Given this list of marker genes LIN28A, REXO1, SUV39H2, CRIPTO, DNMT3L, ASH2L, CCNB1, CBX7, NANOG, DPPA5, KAT6B, here is a description of the gene set: studied in species Mus musculus Human Gene Set: MIKKELSEN_PLURIPOTENT_STATE_UP Somatic cells can be reprogrammed to a pluripotent state through the ectopic expression of defined transcription factors. Understanding the mechanism and kinetics of this transformation may shed light on the nature of developmental potency and suggest strategies with improved efficiency or safety. Here we report an integrative genomic analysis of reprogramming of mouse fibroblasts and B lymphocytes. Lineage-committed cells show a complex response to the ectopic expression involving induction of genes downstream of individual reprogramming factors. Fully reprogrammed cells show gene expression and epigenetic states that are highly similar to embryonic stem cells. In contrast, stable partially reprogrammed cell lines show reactivation of a distinctive subset of stem-cell-related genes, incomplete repression of lineage-specifying transcription factors, and DNA hypermethylation at pluripotency-related loci. These observations suggest that some cells may become trapped in partially reprogrammed states owing to incomplete repression of transcription factors, and that DNA de-methylation is an inefficient step in the transition to pluripotency. We demonstrate that RNA inhibition of transcription factors can facilitate reprogramming, and that treatment with DNA methyltransferase inhibitors can improve the overall efficiency of the reprogramming process. Genes up-regulated in the induced pluripotent cells (iPS) and embryonic stem cells (ES) compared to the parental lineage-committed and partially reprogrammed cell lines. from publication Mikkelsen TS, Hanna J, Zhang X, Ku M, Wernig M, Schorderet P, Bernstein BE, Jaenisch R, Lander ES, Meissner A (PMID 18509334)